Given this list of marker genes GAD2, GAD1, here is a description of the gene set: Reactome Pathway: GABA synthesis studied in species Homo sapiens part of: GABA synthesis, release, reuptake and degradation GABA synthesized uniquely by two forms of glutamate decarboxylases, GAD65 and GAD67, that are functionally distinct and have different co-factor requirements. GAD65 is functionally linked to VGAT, the GABA transporter and selectively GABA synthesized by GAD65 is preferably loaded into the synaptic vesicles. GABA synthesized by GAD67 may be used for functions other than nuerotransmission.